The following is a description of a gene set: Mouse Gene Set: GOBP_INTRACELLULAR_MONOATOMIC_ANION_HOMEOSTASIS A homeostatic process involved in the maintenance of a steady state level of monoatomic anions within a cell. Monatomic anions (also called simple anions) are anions consisting of exactly one atom. studied in species Mus musculus, and this is the list of marker genes: Bsnd, Wnk4, Cacna1a, Kcne3, Ckb, Kcnq1 (potassium voltage-gated channel, subfamily Q, member 1), Stk39, Umod, Abcc2, Fasl, Slc12a5, Tbxas1, Stc1, Spp1, Slc12a2, Ptk2, Wnk1